The following is a description of a gene set: studied in species Homo sapiens Human Gene Set: KAECH_DAY8_EFF_VS_MEMORY_CD8_TCELL_DN Genes down-regulated in effector CD8 T cells at the peak expansion phase (day 8 after LCMV-Armstrong infection) compared to memory CD8 T cells (day 40+ after LCMV-Armstrong infection). How and when memory T cells form during an immune response are long-standing questions. To better understand memory CD8 T cell development, a time course of gene expression and functional changes in antigen-specific T cells during viral infection was evaluated. The expression of many genes continued to change after viral clearance in accordance with changes in CD8 T cell functional properties. Even though memory cell precursors were present at the peak of the immune response, these cells did not display hallmark functional traits of memory T cells. However, these cells gradually acquired the memory cell qualities of self-renewal and rapid recall to antigen suggesting the model that antigen-specific CD8 T cells progressively differentiate into memory cells following viral infection. from publication Kaech SM, Hemby S, Kersh E, Ahmed R (PMID 12526810), and this is the list of marker genes: KLF4, SUN2, FNTB, FOSB, BCKDHB, RGCC, IFT172, SNTB2, CD7, OGFOD2, CHERP, ABHD14A, SOX3, SLC26A2, HOXA9, YES1, SPOUT1, HLA-DOB, RPL6, P2RX4, NLK, CTSS, RASA4, TENT5C, FTL, IVD, TCF7, KCNN4, ZKSCAN3, RERE (NCBI Gene Id 9642), RNF38, GZMM, PER1, RGS10, GBE1, MCOLN2, ERCC2, AFM (NCBI Gene Id 173), RPS4X, SBF2, HNRNPA1, NT5DC3, SNAP47, ZFP36L1, HSD17B8, RREB1, RPL10, DUSP6, CNOT4, PKD1, CTDSP2, FAAH, SLC12A7 (solute carrier family 12 member 7), CCR7, IFNG, DDX5, NR1D2, SMAD7, LAMP1, IL4R, ZNRF1, KCTD12, EEIG1, PARP8, TSR1 (NCBI Gene Id 55720), ABCG1, RPL5, TRAF1, EOMES, DUSP1, VKORC1, SIT1, PRMT3, PNRC1, EIF1, ATF4, ENTPD5, DALRD3, EYA2, ARRB1, MAP4K3, KCNJ8, PDK1, TAPBP, POU2F1, STX1A, JUN, SMAD1, RPS19, CYFIP2 (cytoplasmic FMR1 interacting protein 2), NOP56, WDR74, EGR1, SATB1, NPM1, NOTCH1, ZFP36, NEDD4L, TP53BP1, ADRB2, PCCB, HEXA, TNFAIP6, PRSS12, JUND, SOCS3, RGS2, FBXO21, RALB, MAT2A, IFT88, KLF6, ERAL1, TMX2 (thioredoxin related transmembrane protein 2), RPS6KC1, SSBP2, D2HGDH, SRSF7, IER2, TNFSF8, AXIN1, IDUA, SLC11A2, MYC, NR2C1, IL6ST, MOGS, AQP9, HSD17B11, DNAJB2, EVL, RPGR, C19orf48P, FOXP1, IL7R, NDUFAF4, ZFP36L2, GATA3, PLEKHA1 (NCBI Gene Id 59338), RHOB, IPO4, GALNT10, NUMA1, RPL14, BAG3, ZYG11B, SELL, ANTXR2, SIPA1L2, SKI, NCOA5, RFLNB, ZSCAN26, OVGP1, RABAC1, SLC3A2, RPLP1 (NCBI Gene Id 6176), ZBTB20, SESN1, AKAP9, RETREG1, CCND2, PAM, GADD45A, USF1, VAMP2, ATP13A1, KLHL7, DNAAF10, GSTO1, IFNAR2, XPC, GSTK1, CD28, PIM1, VARS1, CD72, RPS3, DFFA, POU6F1, RBM39, NSG2, RABGAP1L, TLR6, PISD, EML5, IL6R, LY6E, TP53 (NCBI Gene Id 7157), TNFAIP3, BCL2, TDRP, FOS, GALNT11, LARP1 (NCBI Gene Id 91673), LONP1, SETD4, FBL, CDR2